Given this list of marker genes CSF1R, SOD1, TREM2, LSM11 (LSM11, U7 small nuclear RNA associated), PCNA, ABCD1, RNU7-1, GALC, CCNF, OPTN, ADAR, HTT, IDS, PLA2G6, FTH1, GUSB, NEK1, NARS2, LYST, HNRNPA1, ATXN2, C19orf12, SLC2A3, NBN, PPARGC1A, SPTBN1, FA2H, TTC19, GLE1, COASY, ATXN3, NAE1, TXN2, VAPB, MAPT, FUS, SAMHD1, FOLR1, TAF15, AARS2, VCP, PON1, COQ2, CFAP410, EIF4A2, HSD17B10, IDUA, DCTN1, MFSD8, FTL, PDE8B, PRPH, GM2A, GLT8D1, IFIH1, UBTF, TBK1 (TANK binding kinase 1), ANG, NEFH, DLAT, UBQLN2, SQSTM1, RNASEH2B, PFN1, ZBTB20, PON3, TARDBP, PANK2, NAXD, TANGO2, RNASEH2C, WDR45, UNC13A, ERCC6, TREX1, DAO, FIG4, ANXA11, PON2, CHMP2B, MATR3, UCHL1, CHCHD10, ERBB4 (NCBI Gene Id 2066), RNASEH2A, here is a description of the gene set: Progressive loss of neural cells and tissue. Human Gene Set: HP_NEURODEGENERATION studied in species Homo sapiens Neurodegeneration